Given this list of marker genes C3 (NCBI Gene Id 12266), TRAF1, PRMT1, CD19, KDR, SLN, SH2B1, ATP2A1-AS1, SPNS1, NFATC2, INSR, MPL, JAK2, RAB4A, RAB5A, CR2, GRB2, MIR4721, CD82, CD81 (NCBI Gene Id 975), TRAF2, VAV2, SDCCAG8, ATXN2L, IL4, TUFM, LAT, IFITM1, RABEP2 (rabaptin, RAB GTPase binding effector protein 2), RABGEF1, ATP2A1, NFATC2IP (NCBI Gene Id 84901), PLN, here is a description of the gene set: studied in species Homo sapiens 16p11.2 distal deletion syndrome Human Gene Set: WP_16P112_DISTAL_DELETION_SYNDROME